The following is a description of a gene set: Genes down-regulated in comparison of dendritic cells activated in the absense of VAF347 versus those activated in the presence of VAF347. from publication Lawrence BP, Denison MS, Novak H, Vorderstrasse BA, Harrer N, Neruda W, Reichel C, Woisetschläger M (PMID 18270326) species: Homo sapiens Human Gene Set: GSE10463_CD40L_AND_VA347_VS_CD40L_IN_DC_DN VAF347 is a low molecular weight compound which inhibits allergic lung inflammation in vivo. This effect is likely due to a block of dendritic cell (DC) function to generate pro-inflammatory T-helper (Th) cells since VAF347 inhibits IL-6, CD86 and HLA-DR expression by human monocyte derived DC, three relevant molecules for Th-cell generation. Here we demonstrate that VAF347 interacts with the aryl hydrocarbon receptor (AhR) protein resulting in activation of the AhR signaling pathway. Functional AhR is responsible for the biological activity of VAF347 since, i) other AhR agonists display an identical activity profile in vitro, ii) gene silencing of wild type AhR expression or forced over-expression of a trans-dominant negative AhR ablates VAF347 activity to inhibit cytokine induced IL-6 expression in a human monocytic cell line and iii) AhR deficient mice are resistant to the compound’s ability to block allergic lung inflammation in vivo. These data identify the AhR protein as key molecular target of VAF347 and its essential role for mediating the anti-inflammatory effects of the compound in vitro and in vivo., and this is the list of marker genes: ZFHX2, ADGRG7, TMEM255B, RPL12, SNORD123, PPP1R2C, STPG3-AS1, ENSG00000293136, TRIM31, ATP1A4, COL4A4, ADAMTSL2, ALDH3A1, FAM153A, PLAC9, PATE1, AARSD1, SMTNL1, BCL11A, RBMY3AP, PWRN1, FAM230C, SYP, MYH4, PTPRU, CCDC144A, NFATC4, GPX3, PARP8, DCBLD2, FGF14-AS2, HROB, RASGEF1A, REPIN1, EPN1, VCAM1, TINCR, BTBD8, CRB3, WBP2NL, PLEKHA2, DLX1, NRAD1, TARP, C8B, PANX3, ZC3H15, ADCK2, GPR37L1, CRACR2B, DND1, TMEM109, LFNG, RASGRF1, SURF2, KRT16 (keratin 16), SMAD6, KLHL13, MS4A7, RAMP1, ADAMTSL4-AS2, USP5, TRAM2-AS1, OR2K2, KLRG1, ADRA1D (NCBI Gene Id 149), KCTD15, CSTF3-DT, ZNF213, ITIH6, KCNC4, CD160, REN (NCBI Gene Id 5972), TCF24, TDH, KRBOX1, GRPEL1, SKIDA1, NEU2, ECH1, ZSCAN30, MTHFS, FAM24B, PTPRB, ARRDC1-AS1, CLDN15, CAMTA2, AK4, KNDC1, HMGA2, PLAAT1, ASB5, TF, CTSH, MRPS27, KAAG1, PDE11A, C2orf15, PAM16, UGT2B15, ZDHHC1, ERBB3, SMTN (smoothelin), CLDN1, TOP6BL, EPAS1, TMEM174, DENND1B, ENSG00000237870, TLR3, DAPL1, DHH, ARPIN, MXRA8, NPNT, MST1R, ADAM3A, GCNT2, PTPA, ABCC6P1, TMEM102, SNX20, DOCK10, TRBV27, LINC00623, SLC22A17, CCDC28B, MBD3L1, PSG6, CREB3, MRPL24, GTF3A, SEPTIN4, DBP, CES4A, NLGN2, NEU3 (neuraminidase 3), EGOT, INHA, TRG-AS1, COL20A1, H2BC3, NSFL1C, MRM3, IMP4, PKN3, SPAG17, ARHGAP22, THY1, KCNF1, WDR75, IFNB1, RIPPLY2, MICAL1, LZTS1, CNOT7, CCDC142, WNK4, DUSP26, RPS29, SMIM1, FMOD, NPAS3, RIOX1, INMT, NTN5, ATP6V0E2, PRMT1, NUBP2, ADAMTS15, ENTREP3, MPP1, SERPINF2, RBBP8NL (NCBI Gene Id 140893), SMIM17, ARHGEF17, CCDC157, HVCN1, UST, TNFSF11, EFHB, FBXW8, GJB3, ADRB2